The following is a description of a gene set: studied in species Homo sapiens Human Gene Set: TFDP2_TARGET_GENES Genes containing one or more binding sites for (TFDP2) in their promoter regions (TSS -1000,+100 bp) as identified by GTRD version 20.06 ChIP-seq harmonization. from publication Yevshin I, Sharipov R, Kolmykov S, Kondrakhin Y, Kolpakov F (PMID 30445619), and this is the list of marker genes: GMNN, CYB561D2, TPR, NPRL2 (NPR2 like, GATOR1 complex subunit), ODR4